Given this list of marker genes Slc25a5, Oaz1, Pkm, Rcn1, Ddx24, Slc16a1, Car10, Mtf2, Dr1, Luzp1, Rad50, Arfip2, Cnot6l, Vamp3, Hdac4, Epb41l3, Snai2, Klb, Lef1, Kalrn, Myo9a, Mospd1, Tlr3, Tbx20, Exoc6b, Tfdp2, Grhl2, Tmigd1, Lamtor1, Sh3rf2, Fam163b, Jph1, Leprot, Smarcd1, Ipo5, Ptbp2, Fam241a, Hsf5, Slc25a35, Lynx1, Xxylt1, Dagla, P4ha1, Aldoa, Slc1a5, Slc7a1, Ptprj, Foxk2, Dbndd2, Srf, Rbm47, Hsdl1, Olfml3, Usp15, Med1, Fut8, here is a description of the gene set: Genes predicted to be targets of miRBase v22 microRNA mmu_miR_8091 in miRDB v6.0 with MirTarget v4 prediction scores > 80 (high confidence targets). Mouse Gene Set: MIR_8091 species: Mus musculus from publication Chen Y, Wang X (PMID 31504780)